The following is a description of a gene set: species: Homo sapiens Genes up-regulated in CD4 T cells: naïve versus Th1. from publication Zhang W, Ferguson J, Ng SM, Hui K, Goh G, Lin A, Esplugues E, Flavell RA, Abraham C, Zhao H, Cho JH (PMID 22715389) Human Gene Set: GSE32901_NAIVE_VS_TH1_CD4_TCELL_UP In this study, we examined differential gene expression in naïve human CD4+ T cells, as well as in effector Th1, Th17-negative and Th17-enriched CD4- T cell subsets. We observed a marked enrichment for increased gene expression in effector CD4+ T cells compared to naive CD4+ among immune-mediated disease oci genes. Within effector T cells, expression of disease-associated genes was increased in Th17-enriched compared to Th17-negative cells. We used microarray to examine the gene expresssion profile and level of human naïve, Th1 and effector T cell subsets., and this is the list of marker genes: UNKL, ATP6V1B1, CCNB3, PITPNM1, PGAP6, PCDH20, ASPG, ST8SIA1, NR0B1, PHF20L1, IL16, FREM1, ABTB2, PARP14, IRAK3, SEMA4F, KLHL42 (kelch like family member 42), RAPGEF4, AMDHD1, IL23R, ZFP82, LBR, RNF32, CD96, PLCH2, ZUP1 (NCBI Gene Id 221302), VEGFC, PTHLH, KCNB2, KIR3DL1, ZFP57, ESYT2, FABP5P2, C19orf38, CMAHP, PSTK, PDE3B, ELOVL7, SPO11, THEMIS, EXOC8, ARMC7, HTRA4, AQP8, TMEM43 (NCBI Gene Id 79188), ZNRF2, ALS2CL, NUDT18, ACSM2A, SHISAL2A, BGLAP, LATS1, ZNF250, GPRC5B, CAMK1G, PDHA2, KCNK4, NDRG3, EMILIN1, SRPX2, PLPP5, SLC12A7, CHD3, SKAP1, ARAP2, RTP4, IL17RA, TST, RRN3, DPP6, CRACR2A, ENTPD5, CC2D2A, DIO1, CSF1R, NRF1, SMAD7, SLURP1, FLRT2, ENC1, ITGA4, C8B, SENP8, RNASEH2C, ST6GAL1, VIPR1, THBS1, DDX31, PDE2A, KCNH1, EHBP1, CLXN, GTF2I, KLF2, VEZT, COA4, CXCR4, TENT5C, LSMEM2, SCML4, OLFML3, TBC1D4 (TBC1 domain family member 4), WDR86, TMEM79, SLCO3A1, ADD3, PCDHB3, RNF128, SNTB1, RUNDC1, LYPD6B, GRAMD2B, CDKN2AIP, HK3, PARP11, NRARP, GVINP1 (NCBI Gene Id 80073), FBXO41, HDAC5, ADRB2, NUDT19, PTPRB, FAM78A, ST8SIA6, BNC2, SPNS1, HACD1, H2AC6, ARHGEF16, CASKIN1